The following is a description of a gene set: species: Homo sapiens Human Gene Set: HP_RAPIDLY_PROGRESSIVE Applies to a disease manifestation that quickly increases in scope or severity over the course of time. Rapidly progressive, and this is the list of marker genes: DCTN1, PEX10, PSEN1, CRYAB, ATP13A2, SCARB2, EPM2A, DNAJC6, DYSF, SGCG, NAXE, APOE, HLA-DQB1, BAG3, MFSD8, GRN, NPHS2, CSF1R, PLA2G6, GDAP1, SNCA, BET1, DNAJC5, NR1H4, POLG, NPHS1, FHL1 (four and a half LIM domains 1), PLEKHG5 (NCBI Gene Id 57449), PANK2, ARHGDIA, PRNP, C9orf72, TARDBP, PNKP, COQ6, PLEC, LYRM7